Given this list of marker genes Ngp, Usp15, Lcn2, Ubb-ps, Lyz2, Ifitm2, Tmsb10, Iqsec1, Ftl1, Gstm1, Atp5mg, Rpl13a, Tomm6, Bri3, here is a description of the gene set: species: Mus musculus Mouse Gene Set: TABULA_MURIS_SENIS_DIAPHRAGM_B_CELL_AGEING from publication Tabula Muris Consortium (PMID 32669714)